Given this list of marker genes CRISP3, FOLR3, DLX4, TKTL1, OLR1, CCL4, ANXA3, CEACAM8 (NCBI Gene Id 1088), DOCK4, MS4A3, ARG1, TCN1, CAMP, LTF, MMP8, DEFA1B (NCBI Gene Id 728358), DEFA4, here is a description of the gene set: Individuals fail to elicit protective antibody after hepatitis B vaccination remain at risk for hepatitis B virus infection. Analysis of the transcriptome of peripheral blood mononuclear cells (PBMCs) is essential to elucidate the characteristics of gene expression in non-responders. In this study, we enrolled seven responders who had received three injections and seven non-responders who had six injections of hepatitis B vaccine before. All the participants were then vaccinated with a three-dose boost regimen. Microarray analysis and Luminex assay were applied to examine mRNA expression and Th1/Th2/Th9/Th17/Th22/Treg cytokine and chemokine profiles in non-responders and responders. Differentially expressed genes in PBMCs of non-responders at 5 time points, i.e. pre-vaccination, 3<sup>rd</sup>, 7<sup>th</sup>, 28<sup>th</sup> day post the first dose vaccination and 7<sup>th</sup> day post the second dose vaccination indicated a dense network trend. Compared with responders, nine coding genes (BPI, DEFA1B, DEFA4, CEACAM8, MMP8, FOLR3, LTF, TCN1 and TKTL1) were significantly up-regulated in non-responders at all 5 time points, which could probably be the characteristic genes in hepatitis B vaccine non-responsiveness. Gene ontology analysis revealed that most of the DEGs were related with immune responses. Validation results of these genes using quantitative real-time polymerase chain reaction were mostly consistent with the results of microarray. Cytokine analysis demonstrated that IL-27 and CXCL12 concentrations in responders were significantly higher than non-responders on the 3<sup>rd</sup> day after the first dose and 7<sup>th</sup> day after the second dose of vaccination, respectively. No significant difference was observed in other cytokine and chemokine signatures between the two groups. In conclusion, our results revealed characteristic transcriptome and cytokine changes in hepatitis B vaccine non-responders after boost immunization. from publication Qiu S, He P, Fang X, Tong H, Lv J, Liu J, Zhang L, Zhai X, Wang L, Hu Z, Yu Y (PMID 29580160) species: Homo sapiens Genes up-regulated in peripheral blood mononuclear cell non-responders vs responders in adults (<50) after exposure to Heptatitis B surface antigen vaccine (HBsAg), time point 28D Human Gene Set: QIU_PBMC_HEPTATITIS_B_SURFACE_ANTIGEN_AGE_UNDER50_NON_RESPONDERS_VS_RESPONDERS_28DY_UP